The following is a description of a gene set: The interferon-producing plasmacytoid dendritic cells (PDC) share common progenitors with antigen-presenting classical dendritic cells (cDC), yet they possess distinct morphology and molecular features resembling those of lymphocytes. It is unclear whether the unique cell fate of PDC is actively maintained in the steady state. We report that the deletion of transcription factor E2-2 from mature peripheral PDC caused their spontaneous differentiation into cells with cDC properties. This included the loss of PDC markers, increase in MHC class II expression and T cell priming capacity, acquisition of dendritic morphology and induction of cDC signature genes. Genome-wide chromatin immunoprecipitation revealed direct binding of E2-2 to key PDC-specific and lymphoid genes, as well as to certain genes enriched in cDC. Thus, E2-2 actively maintains the cell fate of mature PDC and opposes the “default” cDC fate, in part through direct regulation of lineage-specific gene expression programs. Human Gene Set: GSE24726_WT_VS_E2_2_KO_PDC_DAY6_POST_DELETION_DN studied in species Homo sapiens from publication Ghosh HS, Cisse B, Bunin A, Lewis KL, Reizis B (PMID 21145760) Genes down-regulated in plasmacytoid dendritic cells (6 days after knockout): wildtype versus TCF4 knockout., and this is the list of marker genes: ST7L, ARHGAP39, FBLIM1 (filamin binding LIM protein 1), NCOA1, ADCY7, CDS2, PDCD4, PHC3, APH1B, PHF7, SGCB, BAZ2B, CYTIP, MSL3, FGD2, FXR1, P2RX7, IFIT1, TBX6, ITGA6, TCTN3, BIVM, MXD4 (NCBI Gene Id 10608), GAB2, PLEKHO1 (NCBI Gene Id 51177), RAB11FIP5, GSTM3, ZFHX3, WNK1, CD180, THBD, TPP1, IKZF1, HMOX2, CAMK1, PUM1, ZRANB3, SSBP2, PHF14, TPD52, ANKH, MAN2B1, PRKCH, NRP1, CYP4F3, RNF144B, ITM2C, MAP3K12, FCGRT, NARS1, FAM234A, RCSD1, XIST, GPR34, ATRX (ATRX chromatin remodeler), SNAP23, MBNL3, POLR3GL, RXRB, NIM1K (NIM1 serine/threonine protein kinase), KIAA1143, CNPPD1, RPS11, SP1, LRP1, ABCG1, ADIPOR1, HERC4, EVI2B, NOTCH1, CHD9, CGRRF1, BAIAP2, CNN2, PDLIM5, PHKA2, MGAT5, CD48, SORD, ABCD2, MIER1, FYN, RNF167, FXYD5, CFAP68, ARF4, CITED2, TM9SF2, GLB1, SPTSSA, ARHGAP22, CD300A, PDGFC, ADAMTS10, C1orf21, BLTP3B, SYNGR1, MEF2A, RABGAP1L, IL10RB, WIPF1, RBAK, SAT1, PPP3CA, R3HDM2, TBXAS1, NOSTRIN, GKAP1, APOE (apolipoprotein E), ZDHHC14, PEAK1, KBTBD7, NDNF, PEX7, SCN3B, TBC1D31, TFDP2, MAPRE2, FBXO3, MALAT1, PCK2, RAB40C, GNA13, NUDT4, GPX3, SETD7 (NCBI Gene Id 80854), GALNT14, ARL4C, MTHFS, HPGD, CKB, SSH2, GPR146, PURG, MPP1, TMEM19, AKAP10, YPEL2, NSD3, SLC2A8, ARHGEF6, CD68, BACH1, KIF13B, FGD4, DCLRE1A, TMEM9 (NCBI Gene Id 51235), PTPN18, ARHGAP6, NIBAN1, AGTR2, CAMK1D, NEURL2, PROS1, RAPH1, WLS, RTN4, SOCS6, MIB2, OPHN1, TRIM47, TEC, RASSF3, CCR2, KIFAP3, ENC1, RERE, CD28, APOC2, TMEM64 (NCBI Gene Id 169200), UBN1, GRAMD1B, PLEKHM1, NAGA, TM6SF1, AGMO, LPIN1, RAB3IL1, TPCN1, MAP1LC3B, CCR5, SULF2, RTF2, LPIN2, ZNF704, RAB11B, TCF12, ZXDB, ATP2B1, TSTD1, STMP1, DDX19B, RGS18, POLG2, DHRS7 (NCBI Gene Id 51635), HIGD1C, C3orf33, ARHGAP17, PNPLA7 (NCBI Gene Id 92716), GCNT1